The following is a description of a gene set: Genes predicted to be targets of miRBase v22 microRNA mmu_miR_3073a_3p in miRDB v6.0 with MirTarget v4 prediction scores > 80 (high confidence targets). Mouse Gene Set: MIR_3073A_3P species: Mus musculus from publication Chen Y, Wang X (PMID 31504780), and this is the list of marker genes: Ccdc137, Slc8a3, Rpgrip1l, Trabd2b, Nop58, Spata6l (NCBI Gene Id 70786, spermatogenesis associated 6 like), Zfp677, Gid4, Polr3h, Abce1 (ATP-binding cassette, sub-family E member 1), Sgce, Zfp874a, Serpinb9g, Tex26, Krtap19-1, Cbfb, Styx, Mael, Prkcq, Neb, Mier3, Osbpl8, Pcdh10, Nptxr, Gria2, Pgm3, Ap1b1, Acer2, Crisp4, Spata1, Mier1, Fut9, R3hdm1 (NCBI Gene Id 226412), Raver2, Ube2d3, Mycbp2, Tnrc6b, Unc5c, Serpinb9f, Dock7, B3galnt1, Mapk1, Fam20a, Satl1, Ppp3r2, Thsd7b, Zfp608, Csf2ra, Pik3c3, Magea9, Pkia, Npcd, Ccdc85a, Vwc2, Ctsr, Eny2, Cdh11, Rsl1, Pank2, Nmnat3, Ybx2, Tubb2b, Spata9 (NCBI Gene Id 77955), Ereg, Aqp9, Ubr1, Ammecr1l, Stard13, Nat3, Pdgfa, Tmem230, H2-Q1 (NCBI Gene Id 15006), Col24a1, Gabrb2, Map3k5, Ktn1